The following is a description of a gene set: Condensation of Prometaphase Chromosomes Human Gene Set: REACTOME_CONDENSATION_OF_PROMETAPHASE_CHROMOSOMES studied in species Homo sapiens, and this is the list of marker genes: CSNK2B, CSNK2A2, CSNK2A1, NCAPH, SMC2, NCAPG, NCAPD2, CCNB2, CCNB1, SMC4, CDK1